The following is a description of a gene set: from publication Zhong S, Zhang S, Fan X, Wu Q, Yan L, Dong J, Zhang H, Li L, Sun L, Pan N, Xu X, Tang F, Zhang J, Qiao J, Wang X (PMID 29539641) studied in species Homo sapiens Human Gene Set: ZHONG_PFC_C3_PROX1_CCK_POS_INTERNEURON, and this is the list of marker genes: DLX1, PDZRN3, AP1S2, KITLG, VSTM2A, CALB2, SCGN, CCK, CNR1, ARL4C, PROX1